Given this list of marker genes TAS2R4, ITPR3, TAS2R40, TAS2R13, SCN3A, GRM4, TAS2R46, TAS2R30, TAS2R31, TAS2R14, TAS2R43, TAS2R7 (NCBI Gene Id 50837), TAS2R41, SCN2B, SCN2A, GNB1, TAS1R3, TAS2R50, TAS2R38, SCN4B, TAS2R10, CALHM3, TAS2R16, SCN9A, TAS2R20, TAS1R1, SCN1B (sodium voltage-gated channel beta subunit 1), TAS2R39, TAS2R3, TAS1R2, GNB3, TRPM5, TAS2R5, TAS2R8, CALHM1, GNG13, PLCB2, TRPM4, GNAT3, GRM1, TAS2R1, here is a description of the gene set: part of: Sensory perception of taste species: Homo sapiens Taste receptors for bitter compounds, sweet compounds, and umami compounds (L-glutamate in humans, several amino acids in mice) are G protein-coupled receptors located in type II taste bud cells that signal through a common downstream pathway. Umami ("savoury", L-glutamate) taste receptors are heterodimers of the plasma membrane proteins TAS1R1 and TAS1R3. TAS1R1:TAS1R3 heterodimers also bind 5' nucleotides such as 5' IMP which synergistically augment umami taste. The glutamate receptors GRM1 (mGluR1) and GRM4 (mGluR4) act in an alternative pathway for sensing glutamate in taste cells. Sweet taste receptors are heterodimers of the plasma membrane proteins TAS1R2 and TAS1R3. The glucose transporters SGLT1 and GLUT4 are expressed in type II taste cells and may provide an alternative pathway for sensing glucose. Bitter receptors are a large family of monomeric plasma membrane proteins, the TAS2R proteins.<br> TAS1R-containing sweet and umami receptors and TAS2R bitter receptors are each physically associated with a particular heterotrimeric G protein complex, the gustducin complex, containing GNAT3 (gustducin), GNB1 or GNB3, and GNG13. Upon binding an agonist ligand, the receptor activates the alpha subunit, GNAT3, to exchange GDP for GTP, which results in a conformational change in GNAT3 that causes the receptor-gustducin complex to dissociate, yielding GNAT3:GTP, GNB1,3:GNG13, and the receptor:ligand. The GNB1,3:GNG13 complex binds and activates Phospholipase C beta-2 (PLCB2), which then hydrolyzes phosphoinositol 4,5-bisphosphate (PI(4,5)P2) to yield diacylglycerol and inositol 1,4,5-trisphosphate (I(1,4,5)P3). I(1,4,5)P3 binds and activates the calcium channel IP3-gated Ca-channel type 3 (ITPR3) and ITPR3 then releases calcium ions from the endoplasmic reticulum into the cytosol. The increased cytosolic calcium activates the TRPM5 cation channels, which then transport sodium ions along the concentration gradient from the extracellular region to the cytosol. The depolarization activates SCN2A, SCN3A, and SCN9A channels, which transport further sodium ions from the extracellular region to the cytosol. The depolarization of the plasma membrane opens CALHM1:CALHM3 channels, which transport ATP, a neurotransmitter in the olfactory system, from the cytosol to the extracellular region.<br>Taste receptors were initially discovered in taste buds of the tongue and have now been found in several other tissues including nasal epithelium, the respiratory system, pancreatic islet cells, sperm, leukocytes, and enteroendocrine cells of the gut (inferred from rat and mouse homologs in Wu et al. 2002). Reactome Pathway: Sensory perception of sweet, bitter, and umami (glutamate) taste